Given this list of marker genes CLEC4M, CD209, NECTIN1, PTX3, APCS, TSG101 (tumor susceptibility 101), HIPK2, SIGLEC1, CRP, PPIA, here is a description of the gene set: Binding to a virion, either by binding to components of the capsid or the viral envelope. Human Gene Set: GOMF_VIRION_BINDING studied in species Homo sapiens